The following is a description of a gene set: Recurrent episodes of redness of the skin together with a sensation of warmth or burning of the affected areas of skin. Human Gene Set: HP_FLUSHING species: Homo sapiens Flushing, and this is the list of marker genes: DLST, KIF1B, DEPDC5 (NCBI Gene Id 9681), SDHAF2, SDHB, CACNA1A, SCN9A, NSD1, MAX, NPRL3, VHL, NR3C1, SDHC, SRSF2, MDH2, ATRX, RUNX1, HNF4A, USP48, TET2, CBL, KIT, EPAS1, USP8, BRAF, NF1, FH, TMEM127, HPGD, SDHA, TP53, APC2, NPRL2, RYR1, ASXL1, ATP1A3, ALDH2, SLC25A11, SDHD, ADGRE2, RET, CBS, CDH23, MAOA, ATP1A2, SLC1A3, DNMT3A